The following is a description of a gene set: part of: Diseases of signal transduction by growth factor receptors and second messengers Reactome Pathway: Signaling by ERBB2 in Cancer Gene amplification of the ERBB2 (HER2) oncogene is observed across various different cancer types. In addition to HER2 gene amplification, sequencing of tumour samples have revealed HER2 mutations, which fall within three major regions: the extracellular domain (ECD), transmembrane domain/ juxtamembrane domain (TMD/JMD) and kinase domain (KD). Based on the functional studies of their catalytic activity, signaling and drug sensitivity, as well as their time of occurence with respect to treatment, these mutation can be classified as primary mutations, that can be activating or silent, and may confer drug resistance, and secondary mutations, associated with development of drug resistance upon initial response to targeted therapy.<br><br>Overexpression of ERBB2 (HER2) protein, usually as a consequence of ERBB2 gene amplification, leads to formation of constitutively active, growth factor independent, ERBB2 homodimers, which are sensitive to the therapeutic antibody trastuzumab (herceptin).<br>Co-overexpression of ERBB2 and its dimerization partner ERBB3 leads to formation of both ERBB2 homodimers and ERRB2:ERBB3 heterodimers and is associated with chemotherapy resistance and reduced relapse-free and overall survival.<br><br>Mutations in the kinase domain (KD) of ERBB2 result in constitutive activation of ERBB2 signaling, facilitate heterodimerization of ERBB2 with other EGFR family members and increase the signaling intensity. Functionally studied ERBB2 KD mutants include ERBB2 L755S, ERBB2 L755P, ERBB2 I767M, ERBB2 D769H, ERBB2 V777L, ERBB2 G778_P780dup, ERBB2 T798I, ERBB2 T798M, ERBB2 V842I, ERBB2 T862A, ERBB2 L869R, ERBB2 H878Y and ERBB2 R896C.<br><br>Sensitivity to tyrosine kinase inhibitors (TKIs) and the therapeutic antibody trastuzumab (herceptin) differs between different ERBB2 KD mutants.<br><br>ERBB2 extracellular domain (ECD) mutants harbor missense mutations that lead to substitutions of amino acid residues in the heterodimerization arm contact surface, involved in formation of ERBB2 heterodimers.<br><br>Recurrent missense mutations in regions encoding the transmembrane domain (TMD) and the juxtamembrane domain (JMD) are frequently reported in cancer. TMD and JMD mutations can activate ERBB2 signaling by improving the active dimer interface or by stabilizing the active conformation.<br><br>ERBB2 TMD/JMD mutants differ in their sensitivity to the therapeutic antibody pertuzumab, which blocks ligand-driven heterodimerization of ERBB2. studied in species Homo sapiens, and this is the list of marker genes: PIK3CA, EGFR, HBEGF, NRG2, KRAS, NRAS, EGF, NRG4, SOS1, PTPN12, GRB2, EREG, ERBB4, GAB1, CDC37, ERBIN, ERBB2, PLCG1, BTC, NRG3, PIK3R1, HSP90AA1, HRAS, SHC1, NRG1, ERBB3